The following is a description of a gene set: Top 50 up-regulated genes in cluster CD-1 of multiple myeloma samples with the characteristic expression spike of CCND1. To better define the molecular basis of multiple myeloma (MM), we performed unsupervised hierarchic clustering of mRNA expression profiles in CD138-enriched plasma cells from 414 newly diagnosed patients who went on to receive high-dose therapy and tandem stem cell transplants. Seven disease subtypes were validated that were strongly influenced by known genetic lesions, such as c-MAF- and MAFB-, CCND1- and CCND3-, and MMSET-activating translocations and hyperdiploidy. Indicative of the deregulation of common pathways by gene orthologs, common gene signatures were observed in cases with c-MAF and MAFB activation and CCND1 and CCND3 activation, the latter consisting of 2 subgroups, one characterized by expression of the early B-cell markers CD20 and PAX5. A low incidence of focal bone disease distinguished one and increased expression of proliferation-associated genes of another novel subgroup. Comprising varying fractions of each of the other 6 subgroups, the proliferation subgroup dominated at relapse, suggesting that this signature is linked to disease progression. Proliferation and MMSET-spike groups were characterized by significant overexpression of genes mapping to chromosome 1q, and both exhibited a poor prognosis relative to the other groups. A subset of cases with a predominating myeloid gene expression signature, excluded from the profiling analyses, had more favorable baseline characteristics and superior prognosis to those lacking this signature. from publication Zhan F, Huang Y, Colla S, Stewart JP, Hanamura I, Gupta S, Epstein J, Yaccoby S, Sawyer J, Burington B, Anaissie E, Hollmig K, Pineda-Roman M, Tricot G, van Rhee F, Walker R, Zangari M, Crowley J, Barlogie B, Shaughnessy JD Jr (PMID 16728703) Human Gene Set: ZHAN_MULTIPLE_MYELOMA_CD1_UP species: Homo sapiens, and this is the list of marker genes: TOX2, SLC7A11, GPR63, NID2, ERN1, STC2, CLEC2D, PTGER2, PCDH20, BGLAP, INHBE, TMC6, CSTA, NSUN7, EIF4EBP1, CEBPB, PPP2R5E, PCK2, TBC1D16, FYN, BATF3, KLHL4, TRIB3, ALPK2, HADH, XPOT, PHGDH, ITGAL, TMC8 (NCBI Gene Id 147138), ZNF70, ASB2, ADRB1, RAB33A, GPT2, VPS37A, MFAP4, SESN2, MTG1, RBP1, ATF5, G0S2, TM6SF1, RAB31, RTL5, CTH, SYTL1